The following is a description of a gene set: Human Gene Set: MIR214_3P Genes predicted to be targets of miRBase v22 microRNA hsa-miR-214-3p in miRDB v6.0 with MirTarget v4 prediction scores > 80 (high confidence targets). studied in species Homo sapiens from publication Chen Y, Wang X (PMID 31504780), and this is the list of marker genes: TRAF1, NEO1, MLLT10, NFIA, UBE4A, DOLPP1, EXOC2, HMGN4, RAP1GAP2, IRS1, CRKL, DMXL2, F8, CREBL2, BRPF3, BCL11A, SCAMP4, HMGN3, VSTM4, ZBTB20, MED19, JAKMIP2, PDLIM5, GPN1, ATP2A3, MAK16, AMMECR1L, PGGT1B, RGS22, TMEM33 (NCBI Gene Id 55161), KPNA1, PIK3CB, CTSS, KCNC2, MLXIP, HR, GNAL, ERRFI1, MTM1, ACVRL1, SNX12, COP1, ZFAND3 (NCBI Gene Id 60685), RPUSD1, TANC2, DBNDD2, PCDH20, STK32B, PRR23B, FAM110D, GALNT7, CPEB4, SEC31A, CERT1, SLC25A25, KIF21B, USP24, TBL1XR1, ZFHX3, PHACTR3, RBM34, RALGAPB, GFRA1, CPSF4, MYO1D, SIGMAR1, WDTC1, ADSS2, PPP2CB, FNDC5 (NCBI Gene Id 252995), CMTM4, ZNF214, PHF20L1, TGOLN2, MEAF6, SOX8, CEP44, PELI3, USP20, CACFD1, VAV2, PHF6, BTAF1, KSR1, MMS19, ACSL1, RUBCN, ZNF609, KCNC4, CBL, GSK3B, GDNF, PIM1 (Pim-1 proto-oncogene, serine/threonine kinase), CHD2, CAPN11, PDE5A, CCDC103, SLC25A39, FBXO32, NSD1, CELF1, PROX1, COG5, JPH1, ATP8A1, MECOM, TMEM86A, UBL4B, LHX6, C17orf49, CTNNB1, RPIA, CSF1, C1orf226, GARRE1, TAOK1, PGF, TMEM248, NUFIP2, NOMO3, IL17RD, RAPGEFL1, ZNF710, FAM20B, MTCL2, PARP16, IGSF3, TRA2B, ZBTB39 (zinc finger and BTB domain containing 39), CXXC5, RFX7, TWF1, DUSP15, MTMR3, DAGLA, ARL2 (ADP ribosylation factor like GTPase 2), RC3H1, MPI, USP3, ARID3B, MAPK1, PYM1, SARM1, YWHAZ, LSM12, TSPAN11, MBLAC2, NFATC2, MTA3, CBX2, GPR85, RNF169, KIF13A, PTER, TMEM161B, CLSTN1, DBNDD1 (NCBI Gene Id 79007), RAB4B, SPTBN2, IPO7, NMB, CPEB1, MFN2, DHRS12, ZBTB10, ITGB8, PAN2, PPP6C, OPRK1, AKAP13, INO80C, MAPK8, ATP6V0E2, UBE2R2, ATG16L1, GALNT18, CNIH1, PCLO, BTBD1, ST6GALNAC1, SMYD5, NAA50, LUZP1, LARP1, SLC36A1, QKI, BAX, TAFA4, MAP3K4, SLC23A2, ATP8B2, PID1, RIMS3, SEC24C, PDE11A, PRR14L, RCSD1, EDF1, IKBKB, TMEM43, PLA2G3 (phospholipase A2 group III), LRP2, GATD3, PCMT1, RHPN1 (NCBI Gene Id 114822), KMT5A, HMG20A, NEURL1B, KRTAP4-4, PURB, KBTBD2, USP46, SLC8A1, CBR4, HPSE2, BCL2L11, EXOC3L2, FGF14, TNPO1, CLASP1, DLL1, BAZ2A, OXR1, GLOD5, FGFR1, PLAGL2, VPS53, IPO11, GCC2, TRAF3, PPM1L, KIF7, ERFE, RAB14, FBLN5, NECTIN1, NAA15, PLXDC1, ALPK2, GPR6